The following is a description of a gene set: Mouse Gene Set: REACTOME_SHC1_EVENTS_IN_ERBB2_SIGNALING studied in species Mus musculus SHC1 events in ERBB2 signaling, and this is the list of marker genes: Nrg3, Ereg, Egf, Prkcd, Egfr, Prkce, Erbb4, Btc, Nrg1, Ptpn12, Hbegf, Shc1, Erbb2, Erbb3